The following is a description of a gene set: Genes predicted to be targets of miRBase v22 microRNA hsa-miR-3085-3p in miRDB v6.0 with MirTarget v4 prediction scores > 80 (high confidence targets). from publication Chen Y, Wang X (PMID 31504780) Human Gene Set: MIR3085_3P studied in species Homo sapiens, and this is the list of marker genes: ZNF544, FZD5, ZBTB3, MMD2, MYH9, KCNK9, TMEM245, LZTS1, ZNF850, KLHDC3, ZNF782, KCNN3, SIX4, MFSD11, PPP3R1, BAG4 (BAG cochaperone 4), BAIAP2L1, DDX3Y, VPS33A, PRR15L, CAPN6, SH3BGRL3, TCEANC2, TFCP2L1, FRMD4A, EIF5, CLIC6, GPN2, TANC2, SMURF1, TXNIP (NCBI Gene Id 10628), ATP1B4, AAK1, FBXO17, LMX1B, JADE2, UBE2QL1 (ubiquitin conjugating enzyme E2 QL1), UBIAD1, CHST3, CACHD1, ZNF74, FYCO1, NR4A3, PHLDB1, CSNK1G1, SEZ6, HEMK1, LDLRAD3, SLC4A8, CNN3, PIK3CB, MECP2, AGO1, RHOJ, PTPRT, JPH1, IL1R1, HSPB6, SAV1, IGFBP5, HMOX2, PAN3, DHCR24, GALNT10, VPS4A, PIK3R6, PCDH20, IDH2, R3HDM4, SLC26A9, PRDM10, BTBD6, ZFAND3, LRGUK, CLOCK, REPS2, EDAR, PRDM4, AREL1, ATP10B, MRPL52, ZNF582 (NCBI Gene Id 147948), PTPRJ, TRAPPC3L, SLC36A1, MSRB2, AP1M1, ZNF12 (NCBI Gene Id 7559), R3HDM1, HNMT, ZNF747 (NCBI Gene Id 65988), STK38, SORT1, PLXNA2, GFER, CIMAP2, CLASP2, ZNF471, SRGAP2, PHF21A, BMF, CRY2, ADD1 (NCBI Gene Id 118), RASSF8, CNOT10, ANKRD36, ARHGAP21 (Rho GTPase activating protein 21), TMEM178B, SLC26A1, NDST1, CCDC186, NECTIN4, RHOF, P2RX7, SPRED2, CRIM1, CA10, TBC1D2B, CLIP2, TBL1X, SUMF2, ODR4, FAM107B, PPP4R2, DNAJB9, AP1G1, DKK3, PNO1, LEMD2, NUDT15, PAX5, GABRB2, EVC, WASHC4, TBC1D16, PIP4K2B, ADCY1, CMTM4, RSBN1L, JOSD1, ZNF37A, GLDN, TNFRSF25, APPL2, OGT, ELP5 (elongator acetyltransferase complex subunit 5)